Given this list of marker genes NUP160, SPC25, PPP2CB, KIF18A, CENPF, BUB3, PPP1CC, CENPE, CKAP5, DYNLL2, RCC2, KNL1, DYNC1LI1, CENPL, SKA1, NUP37, CDCA8, AHCTF1, SPC24, NDC80, ZWINT, CENPI, PPP2R1B, NSL1, PPP2R5B, CENPC, PPP2R5A, PPP2R5E, KIF2B, PLK1, NUP98, KIF2C, CENPS, DSN1 (NCBI Gene Id 79980), SEC13, DYNC1I2, PPP2R5D, NUDC, RANGAP1, NDE1, BUB1, KIF2A, DYNC1I1, XPO1, SGO2, BIRC5, CENPM, SPDL1, CENPA, KNTC1 (NCBI Gene Id 9735), CENPN, DYNC1H1, RANBP2, PPP2R5C, AURKB, CENPO, SEH1L, CLIP1, MAD2L1, NUP43, CENPU, CENPK (NCBI Gene Id 64105), ZWILCH, MIS12, MAPRE1, CENPT, PMF1, ITGB3BP, TAOK1, INCENP, ZW10, CLASP1, CENPH, SGO1, RPS27, CENPQ, DYNC1LI2, MAD1L1, ERCC6L, NUF2, B9D2, PPP2CA, NUP85, DYNLL1, PAFAH1B1 (NCBI Gene Id 5048), CDC20 (cell division cycle 20), NDEL1, CENPP, NUP133, PPP2R1A, SKA2, BUB1B, CLASP2, NUP107, here is a description of the gene set: The signal from unattached kinetochores is amplified through a Mad2 inhibitory signal that is propagated by the binding of Mad1 to the kinetochore, the association of Mad2 with Mad1, the conversion of Mad2 conformation to an inhibitory form through its association with Mad1 and finally the release of the inhibitory form of Mad2 from the kinetochore. species: Homo sapiens Reactome Pathway: Amplification  of signal from unattached  kinetochores via a MAD2  inhibitory signal part of: Amplification of signal from the kinetochores